The following is a description of a gene set: Genes predicted to be targets of miRBase v22 microRNA mmu_miR_467a_3p in miRDB v6.0 with MirTarget v4 prediction scores > 80 (high confidence targets). studied in species Mus musculus from publication Chen Y, Wang X (PMID 31504780) Mouse Gene Set: MIR_467A_3P, and this is the list of marker genes: Vmp1, Sh3rf1, Rgmb, Ppp1r21, Vwc2l, Asf1a, Usp29, Tmem236, Nkx2-9, Far1 (NCBI Gene Id 72904), Myf6, Crx, Spag9, Whamm, Ncf1, Itga4, Hbp1, Tanc2, Nexmif, Cxcl16 (NCBI Gene Id 66102), Ptp4a1, Nufip2, Yy1, Ptprr, Cspp1, Gstt3, Ncald, Bmp5, Cbln4, Rnf24, Grm5, Ndnf, Tmc8, Xiap, Sms, Ccdc166, Ifrd1, Ino80d, Gabrb3, Trh, Ssbp2, Fgd4, Rabggtb, Ss18l1, Bmpr1b, Cntrob, Ctr9 (NCBI Gene Id 22083), Hectd1, Adgrl2, D630023F18Rik, Cpne3, Dleu7, Col11a1, Slc38a2, Tmem33, Arid1a, Zfp280d, Ccn3, Dlx4, Crybg3, Usp42, Car10, Vezf1, Itfg1, Pcsk2, Fut9, Usp7, Zfp518b, Zfp608, Camta1, Plac9, Kif11, Tnrc6b, Slc4a7, Stam2, Bltp1 (NCBI Gene Id 545514), Hivep2, Inpp5b, Myf5, Dll1, Arl14epl, Bri3bp, Psmd5, Hes1 (hes family bHLH transcription factor 1), Foxa1, Zfp292, Nog, Wdr44, Rab11fip2, Hoxd1, Adam22, Mbnl1, Mycn, Jcad, Zfp182, Trappc6b, Sbf2, Timm10, Itm2c, Extl3, Irx5, Spred1, Cav2, Slc6a8, Manea, Zbtb49, Marchf5, Aebp2, Dbx1, Cnnm4, Or52n4, Alg1, Casz1, Marchf6, Kcna2, Nsd1, Glcci1, Itch, Igfbp1, Eid2, Paxbp1, Optn, Opa1, Eda, Cacna1c, Kdm3a (lysine (K)-specific demethylase 3A), Zfp831, Ppm1k, Spry1, Cyth3, Esrrg, Fgf4, Inpp4a, Cttnbp2, Chd1, Rock2, Spindoc, Oga, Sox9, Arl6ip6, Syncrip, Snrk, Kdm6a, Mef2a, Tiam1, Pip5k1b, Bcl11b, Nr5a2, Slc30a4, Rbm5, Cks2, Dnajc6 (NCBI Gene Id 72685), Golt1a, Adamts20, Psd3, Fzd8, Lypd1, Apobec3 (NCBI Gene Id 80287), Tmprss11e, Pcdh8, Arhgap29, Fgf12, Rif1, Nom1, Gpr183, Bcl2l11, Nphp3, Nopchap1, Pik3r1, Serpini1, Col5a1, Cnot6l, Clspn, Vps33b, Il18rap, Trib1, Smad9, Tmem68 (NCBI Gene Id 99971), Lemd3, Hook3, Ing1, Rgs4, Ptch2, Ifngr1, Prpf4b, Zfp606, Chmp4c, Cacnb2, Slc34a2, Tbr1, Gpcpd1, Nkx2-1, Kmt2c, Adamts5, Brd3, Slc20a2, Susd6, Trhr, Pou3f2, Spry2, Aftph, Mbd2, Nptn, Cdc42ep3, Zswim6, Zfp354c, Ppp1r14c, Steep1, Lats1, Stat3, Dennd2b, AI182371, Sez6l, Magoh, Epc2, Fgfr2, Rbl1, Naaladl2, Pcdh11x (protocadherin 11 X-linked), Cadm1, Diaph2, Rab6b, Mitf, Arhgef7, Glis1, Dmxl1, Anks1b, Ints6, Atl2, Pappa, Foxj2, Brd1, Atp2b4, Ano1, Arap2, Ednra, Sp100, Etaa1, Gtf2b, Dpm1, Ccnc, Zfp248, Thbs2, Zmym3, Htr5a, Adgrb3, Rnf4, Mbnl3, Ppp2cb, Taok1, Zc2hc1a, Syngr3, Wsb1, Pdgfra, Crebzf, Arih1, Sik1, Cldn23, Ralyl, Lgr4, Rras, Plag1, Smoc1, Fech, Zbtb44, Rab3c, Malt1, Meox2, Rassf5, Irx3, Arid5b, Loxl3, Psma3, Eps8, Tmem196, Cab39, Paip1, Kbtbd2, Slc25a16, Spryd7, Bnc1, Fa2h, Sfrp2, Pum1, Slc39a10, Grk5 (G protein-coupled receptor kinase 5), Ankrd1, Dcun1d4, Zfyve21, Fbxl17, Cdc14a, Tspan2, Plekhg1, Cecr2, Zxdb, Vcan, Hsf2, Pclo, Cadm2, Gopc, Ash1l, Brcc3, Hnrnpdl, Mtf2, Gucy1a2 (guanylate cyclase 1, soluble, alpha 2), Ubap2l, Sox21, Pafah1b2, Mphosph9, Myorg, Mob4, Pcf11, Pgr, Kif20b, Adam9, Tec, Cds2, Hecw2, Nbea, Btf3l4, Rbm25, Il1rap, Cobll1, Trpc1, Arhgef10l, Slc6a19, Pter, Ercc3, Gm15881 (predicted gene 15881), Asic4, Irx1, Sema3d, Zcchc24, Grb2, Tgfbr1, Dlc1, Mzt1, Tmem178, Raph1, Tspoap1, 1110059E24Rik, Sos1, Efr3b, Tspan12, Kics2, Dock1, Nlgn1, Bbx, Dach1, Wnt5a, Arl8a, Tbc1d15, Pou4f2, Msantd2, Tcf7l2, Dll4, 5730455P16Rik, Pdik1l, Asap1, Arpp21, Tet1, Rpain, Ice1, Cry1, Hopx, Zfp518a, Fam171a1, Mcl1, Lmbr1, Simc1, Foxo1, Atad5, Morf4l2, Slc35a3, Cyp26b1, Zcchc8, Prkcd, Ccdc126 (coiled-coil domain containing 126), Evi2b, Plch1, Hexim1, Ppp1r26, Arhgap44, Fbxo30, Adamtsl3, Rbm27, Ccr2, Ttc8, Eml6, Dsc1, Usp12, Pnrc1, Srek1ip1, Xrcc2, Crebrf, Mbd5, Rnf38, Kif23, Phactr4, Mysm1, Pafah1b1 (platelet-activating factor acetylhydrolase, isoform 1b, subunit 1), Foxc1, Suv39h1, Ugcg, Akap9, Pitx2, Rb1cc1, Hmcn1, Adarb1, Kit, Srgap3, Dcun1d3, Fam199x, Zfp236, Thrb, Pdap1, Cxadr, Pmp22, Mast4, Arhgap12, Nemf, Lef1, Tm4sf4, Vps13d (vacuolar protein sorting 13D), Dek, Ndel1, Rasgrf1, Traf3ip1, Arhgap6, Lmo1, Cysltr1, Fam174a, Hnf4g, Oprk1, Slc5a1, Ing3, Rasgef1a, Cdk19, Grm3, Hs6st2, Ccna2, Jag1, Trim63, Epc1, Sos2, Creld2, Ap1b1, Terb2, Dclk2, Zfx, Sestd1, 9330159F19Rik, Col19a1, Rab18 (RAB18, member RAS oncogene family), Ogfrl1, Slc1a2, Capn1, Galr1, Carmil1, Chic1, Hat1, Cd200r1, Vegfa, Sv2b (synaptic vesicle glycoprotein 2b), Scamp2, Vcam1, Casd1 (CAS1 domain containing 1), Usp6nl, Hoxa9, Tet2, Foxd4, Golga2 (golgin A2), Slc30a10, Prdm1, Crim1, Insm2, Cbx5, Cdkn1b, Fbxo33 (NCBI Gene Id 70611), Vcf2, Trp53inp1, Dapk1, Adck1, Orc1, Lin28a, Plcb1, Tshz3, Nek1, Lin54, Sstr1, Rbbp9, Xrn2, Mamdc2, Clip1, Gm5592 (NCBI Gene Id 434172), Erbb4, Acr, Dpp6, Naa15, Slc30a5, Spc25, Calhm5, Klf12, Znrf3, Kif3a, Cflar, Zbtb14, Zfp131, Ctdspl2, Slc23a2, Aqr, Rbm39, Bnip2, Foxj3, Arid4b, Rabgap1, Carf, Strn3, Ptpra, Lamtor5, Prkce, Mab21l1, Erich1, Mtor, Nfyb, Csmd1, Slitrk6, Lipg, Id1, Prkg2, Ccdc185, Ism1, Sun1, Slc38a1, Ccnb1, Slc8a1, Daam1, Ric3, Efcab14, Epha5, Dagla, Usp31, Gpkow, Map4, Ikzf2, Twist1, Pdzrn3 (NCBI Gene Id 68638), Mrtfa, Zic3, Zic1, Ccar2, Spink5, Pitpnb, Nsmce4a, Cic, Akap6, Homer1, Zfp148, Cldn17, Prkaa1, Klf2, Nusap1, Atad1, Pum2, Pten (NCBI Gene Id 70161), Med6, Hhip, Ctdsp1, Tek, Nup35, Stx12 (NCBI Gene Id 100321), Akap12, Cnot2, Wee1, Jrkl, Camsap2, Dmtf1, Hmgxb4, Ccdc102a, Nr1h5, Adcyap1 (adenylate cyclase activating polypeptide 1), Tfb1m, Fbxo45, Denr, Nodal, Ube2w, Tbx18, 1110059G10Rik, Bmper, Rab2a, Zbtb22 (NCBI Gene Id 81630), Zc3h7b, Adamts1, Scai, Lcorl (ligand dependent nuclear receptor corepressor-like), Robo2, Nceh1, Gabra2, Fhip2a, Mosmo, Necap1, Rab3gap2, Rasef, Abi1, 1810062G17Rik, Ppp1r7, F3, Btbd7, Zfp93, Kcnh5, Prkacb, Adgrg2 (adhesion G protein-coupled receptor G2), Rai1, Taf4b, Ank3, Unk, Nfat5, Prkar1a, Stk24, Nectin4, Dnajb12, Fbxo43, Abca8a, Ets2, Fam76b, Zc3h12c, Irs1, Stk17b, Tm9sf3, Hnrnpr, Lmo3, Tut4, Antxr1, Acp2, Slc7a11, Igf2r, Zfp715, Phf6, Cntfr, Msi2, Tmed7, Herc2, Mef2c, Syt1, Stard8, Dnm2, Wnt3, Uty, Cep192, Emp2, Slc28a3, Npy, Zbtb10, Pgm2l1, Camk2d, Tab3, Stx7, Ppat, Nedd9, Ppp1r15b, Cxcl5, Tcf12, Leprotl1, Vps26a, Abca14, Cbfb, Met, Tmprss11b, Tubgcp5, Mycbp2, Fam43a, Rcan2, Nfkbia, Bche (NCBI Gene Id 12038), Nr3c1, Snx14, Man1a2, Rsrp1, Otud4, Amotl2, Evx2, Ensa, Zc3h4, Dock3, Zmym2, Baz2b, Dnm3, Ncoa2, Bdnf, Utp18, AW554918, Ttc7 (tetratricopeptide repeat domain 7), Klf4, Plekhg5, Gdap2, Itga2, Vstm4, Btaf1, Btnl9, Rab11fip1, Pkd1, Ddx60, Efna5, Grhl3, Jph1, Klf15, Adamts17, Lrrc42, Avl9, Nup133, Slc7a1, Snx12, Gsk3b, Irf2bp1, Myo5b, Impact, Cilk1, Stard13, Plxna2 (plexin A2), Ptpre, Col25a1, Mrpl39, Prickle1, Fnbp4, Camk1d, Prdm16, Gabrb2, Sstr2, Iqca1, Nedd4l, Gnb4, Cdr2, Ppp2r5e, Lzts2, Pias1, Mtmr6, Sncaip, Stxbp5l, Rasal2, Pik3ca, Ahdc1, Ttll7, Fat3, Zc3h11a, Sorcs3, Fndc3b, Fnip1, Cggbp1, Mbtd1, Topbp1, Rab8b, Acvr2b, Rfx8, Exosc7, Ythdc2 (NCBI Gene Id 70219), Tmem161b, Penk, Iars2, Twist2, Tbc1d4, Foxq1, Gas1, Phf12, Ppm1h, Syvn1, Ptbp3, Ripply2, Pik3c2a, Kitl, St8sia4, Erlec1, Myct1, Mfsd2a, Nktr, Gtpbp2, Hivep1, Wipf3, Slmap, Zbtb7a, Map3k8, Edem3, Tafa1, Scn2a